Given this list of marker genes Kcnk18, Bard1, Lingo4, Khdc4, Fbxo43, Hp1bp3, Oasl1, Acer2, Ark2c, R3hdm2, Srf, Larp1, Sod3 (NCBI Gene Id 20657), Oas3, Abitram, Epha4, Jcad, Vps39, Scp2, Ghrhr, Zkscan8, Mcmbp, Zfp207, Zfp710, Il23r, Il2ra, Krtap16-3, Casp8, Clcn6, Xaf1 (XIAP associated factor 1), Znrf1, Prkag1, Phyhipl, Kcnq5, Csde1, C1qtnf1, Pomk, Ip6k2, Mta2, Dipk1a, Kpnb1, Mab21l3, Cd4, Dgkk, Kcnma1, Cd38, Scn3b, Syt6 (NCBI Gene Id 99876), Clec4f, Ppp1r13l, Cbfa2t2, Cps1, Gkn2, Col6a5, Zfp410, Lypla2, Zfp94, Zbtb37, Osbpl5, Csnk1d, Zfand3, Timmdc1, Selenoi, Stxbp2, Slc46a3, Fbxl17, Kazn, Bcl9, Paqr4, Rasa1, Prrg3, Galnt9, Necab1, Gad1, Cnr2, Foxn2, Snu13, Dctn6, Ctcf, Sema6d, Serpina3c, Pla2g15, Dnmt3a, Zfp280c, Utp6, Fkbp4, Micall1, Nexmif, Idh3a, Pbx1, Srl, Amotl1, Slc2a12, Ndufaf5, Thumpd2, Patl1, Fbxw4, Icmt, Grm5, Trim67, Rab43, Gm13288, Dtx4, Dek (DEK proto-oncogene), Tbc1d9b, Glud1, Mecp2, Smpd3, Zim1, Timp3, Tdpoz8, Zfp212, Lrtm2, Ugt2b1, Serpina3k, Abcg1, Kif21b (kinesin family member 21B), Serpinf2, Commd8, Ogn, Ucp2, Slc10a7, Phaf1, Add2, Smc3, Larp4, Megf11, Dhrs9, Cplx1, Cep72, Msantd2, Pja2, Card6, Abcg4, H2-M10.5, Naaladl2 (N-acetylated alpha-linked acidic dipeptidase-like 2), Gstm6, Nfia, Sec61a2, Cep20, Sidt2, Ptgfrn, Hcfc1r1, Dnm3, Ccdc127, Rreb1, Plxna1, Edem1, Gcnt1, Ppp1r1c, Minar2, Pdcd7, Tgif1, Nherf1, Tgfbrap1, Mfsd14b, Taf4b, Zfp609, Cdh4, Tubal3, Dlg4, Mllt6, Ntsr1, Sestd1, 2310022A10Rik (NCBI Gene Id 66367), Mtcl2, Aamp, Hcls1, Krtap4-1, Cd99l2, Xpo7, Zbtb2, Arih1, Psd3, Trim34a (tripartite motif-containing 34A), Mmp20, Lyve1, Ralgapa1, Zfp704, Pfkfb3, Lrrc41, Rimkla, Mif4gd (MIF4G domain containing), Efna3, Mtf1, St3gal2, Esr1, Kcnv1, Bri3bp, Bbs9, Wnt2, Calm2 (calmodulin 2), Clasp2, Ccdc71l, Sgo1, Btf3l4, S1pr2, Pabpc4l, Rfk, Nrxn3, Pex19, Sv2b, Daam2, Zfp646, Cyp2s1, Atp1b2, Atf7, Rusc1, Psme3, Samd10, Wnt2b, Fcer2a, Dnajc11, Slc5a7, Slc41a1, Rab1b, Spop, Mllt3, Gas7, Dtna, Cavin2, Ncbp2, Tyrp1, Jak3, Ap1s2, Fmnl3, Tmem43, AI597479, Fam187b, Rab5c, Nxn, AI593442, Ston2, here is a description of the gene set: Mouse Gene Set: MIR_7074_5P species: Mus musculus from publication Chen Y, Wang X (PMID 31504780) Genes predicted to be targets of miRBase v22 microRNA mmu_miR_7074_5p in miRDB v6.0 with MirTarget v4 prediction scores > 80 (high confidence targets).